Given this list of marker genes Ripk3, Ripk1, Sarm1, Ube2d2a, Ubc, Ticam2, Tlr4, Traf6, Ube2n, Ube2d3, Ube2d1, Uba52, Ikbkb, Birc2, Ticam1, Ubb, Uba52rt, Ube2v1, Ly96, Birc3, Chuk, Ikbkg, Cd14, Rps27a, here is a description of the gene set: IKK complex recruitment mediated by RIP1 Mouse Gene Set: REACTOME_IKK_COMPLEX_RECRUITMENT_MEDIATED_BY_RIP1 species: Mus musculus